Given this list of marker genes STRIP2, MXD4, MEF2D, GMCL1 (NCBI Gene Id 64395), GLS, DEFA1B, FADD, CARHSP1, PIK3IP1, PRKDC, FKBP11, HSD17B12, KLHL22 (NCBI Gene Id 84861), NCALD, TOX2, NMNAT3, CXCR6, KYAT1, ANKRD33, EML3, CCDC92, here is a description of the gene set: from publication Franco LM, Bucasas KL, Wells JM, Niño D, Wang X, Zapata GE, Arden N, Renwick A, Yu P, Quarles JM, Bray MS, Couch RB, Belmont JW, Shaw CA (PMID 23878721) Identification of the host genetic factors that contribute to variation in vaccine responsiveness may uncover important mechanisms affecting vaccine efficacy. We carried out an integrative, longitudinal study combining genetic, transcriptional, and immunologic data in humans given seasonal influenza vaccine. We identified genes exhibiting a transcriptional response to vaccination, significant genotype effects on gene expression, and correlation between the transcriptional and antibody responses. The results show that variation at the level of genes involved in membrane trafficking and antigen processing significantly influences the human response to influenza vaccination. More broadly, we demonstrate that an integrative study design is an efficient alternative to existing methods for the identification of genes involved in complex traits. DOI:http://dx.doi.org/10.7554/eLife.00299.001. Genes negatively correlated with antibody response in blood in adults (18-40) after exposure to Sanofi Pasteur, SA, Inactivated influenza vaccine, time point 1D studied in species Homo sapiens Human Gene Set: FRANCO_BLOOD_SANOFI_PASTEUR_SA_INACTIVATED_INFLUENZA_VACCINE_CORRELATED_WITH_ANTIBODY_RESPONSE_AGE_18_40YO_1DY_NEGATIVE